Given this list of marker genes NT5C, AMPD3, ADSL, PFAS, AMPD2, AMPD1, PNP, GART, APRT, ADSS2, XDH, HPRT1, NT5C1A, ADSS1, ATIC, PPAT, PAICS (phosphoribosylaminoimidazole carboxylase and phosphoribosylaminoimidazolesuccinocarboxamide synthase), NT5C2, here is a description of the gene set: The chemical reactions and pathways involving IMP, inosine monophosphate. Human Gene Set: GOBP_IMP_METABOLIC_PROCESS species: Homo sapiens